Given this list of marker genes PCSK1, YY1, UCP2, HNF1A, GLUD1 (glutamate dehydrogenase 1), MEN1, ALDOB, here is a description of the gene set: Human Gene Set: HP_REACTIVE_HYPOGLYCEMIA Hypoglycermia following a meal (or more generally, after intake of glucose). studied in species Homo sapiens Reactive hypoglycemia